Given this list of marker genes EGF, WNT5B, LGR4, SIX1, WNT2B, NOG, MAGED1, VEGFA, AGTR2 (angiotensin II receptor type 2), LBX2, BMP4, GATA3, SMO, WNT4, PAX2, LCN2, PAX8, ABL1, MMRN2, LIF, CTNNB1, LHX1, GDNF, AR, HOXB7, TGFB1, SOX9, STOX1, FGF2, SOX8, ITGAX, GJA1, GREM1, PIK3CD, SIX4, SIRT6, MDK, AGT, here is a description of the gene set: Any process that activates or increases the frequency, rate or extent of morphogenesis of an epithelium. studied in species Homo sapiens Human Gene Set: GOBP_POSITIVE_REGULATION_OF_MORPHOGENESIS_OF_AN_EPITHELIUM